The following is a description of a gene set: Human Gene Set: REACTOME_RUNX2_REGULATES_CHONDROCYTE_MATURATION RUNX2 regulates chondrocyte maturation species: Homo sapiens, and this is the list of marker genes: GLI2, HDAC4, RUNX2, IHH, CBFB